The following is a description of a gene set: An AP-type membrane coat adaptor complex that consists of beta4, epsilon, mu4 and sigma4 subunits and is found associated with membranes in the trans-Golgi network; it is not clear whether AP-4 forms clathrin coats in vivo. Mouse Gene Set: GOCC_AP_4_ADAPTOR_COMPLEX species: Mus musculus, and this is the list of marker genes: Ap4b1, Ap4s1, Ap4e1, Tepsin, Ap4m1